Given this list of marker genes Prdm16, Ehmt2, Suv39h2, Mecom, Prdm8, Setd5, Ehmt1, Setmar, Suv39h1, Setdb2, Setdb1, Ash1l, Prdm9, here is a description of the gene set: species: Mus musculus Catalysis of the reaction: S-adenosyl-L-methionine + histone H3 L-lysine (position 9) = S-adenosyl-L-homocysteine + histone H3 N6-methyl-L-lysine (position 9). This reaction is the addition of up to three methyl groups to the lysine residue at position 9 of the histone H3 protein. Mouse Gene Set: GOMF_HISTONE_H3K9_METHYLTRANSFERASE_ACTIVITY